The following is a description of a gene set: species: Homo sapiens Human Gene Set: GOCC_ENDOCYTIC_VESICLE_MEMBRANE The lipid bilayer surrounding an endocytic vesicle., and this is the list of marker genes: RAB39A, HVCN1 (NCBI Gene Id 84329), NOS3, SLC9A9, TAPBP, RAB11FIP1, SYT7, SNAP23, TAP2, TLR2, CACNG2, TLR6, IRGM, RAB9A (RAB9A, member RAS oncogene family), SH3GL2, ENTPD7, SYT2, NOSTRIN, RAB8A, ATG5 (NCBI Gene Id 9474), FZD2, MSR1, CLTC, RAB11A, EPGN, ATP6V0D2, LDLRAP1, DLG4 (discs large MAGUK scaffold protein 4), ATP7A, WASL, TCIRG1, TBC1D5, CD9, PICK1, WLS (Wnt ligand secretion mediator), LDLR, FCGR1A, CD74, WNT7A, HLA-H, APPL2, ATP6V0E2 (ATPase H+ transporting V0 subunit e2), CYBB, WNT1, TAP1, SCARF1, HLA-DQA2, CD4, UBC, UBB, DNM2, UBA52, AP2M1, CFTR, ATP6V0A1, CALR, MTMR4, RAB9B, LRP2, ARRB1, HLA-G, HLA-F (NCBI Gene Id 3134), TFRC, HBEGF, AP2B1, TGFA, HLA-DPA1, ADRB2, ATP6V0D1, HLA-DPB1, VAMP2, MARCO, DYNC1LI1, RAC2, WNT6, CAMK2A, HLA-DRB1, RAB11FIP3, AVP, WNT3A, RAB20, AP2A1, ANXA3, CD36, RAB8B, CHRM2 (NCBI Gene Id 1129), APOB, CACNG8, CAMK2B, HLA-B, EREG, CSF3R, PIKFYVE, RAB11B, CD3D, LAMP2, GRIA2, PIK3C3, DMBT1, FZD4, WNT4, MDM2, B2M, SGIP1, LAMP1, SYT1, ATG12, HLA-DRB3, COLEC12, TLR1, RAB7A, VAMP8, CAMK2D, SLC18A3, AP2A2, PIP4P2, ARRB2 (NCBI Gene Id 409), EGFR, CD207, ATP6V0A4, CYBA, RPS27A, PTCH1, ATP6V0A2, SLC15A2, MPEG1, HLA-C, STON2, BTC, INPP5B, IL7R, GRIA1, RILP, ATP6V0E1, SCARB2, BTBD8, SMO, STX4, LRP1, RAB32, CACNG4, FZD5, STON1, KIAA0319, RAB43, RAB23, SLC2A8, PIK3R4, ROR2, RAB31, CAMK2G, STAB1, TYRP1, FCGR1BP, GRIA4, SYT9, WNT5B, HLA-DQA1, EPS15, RAB38, PIP4P1, RAB35, CAV1, HLA-DQB1, SLC48A1, VAMP7, WNT7B, ACE2, GRIA3, HLA-DRA, M6PR, VAMP4, AP2S1, MCOLN1 (NCBI Gene Id 57192), TGOLN2, ATP6V0C, HLA-DRB4 (major histocompatibility complex, class II, DR beta 4), VAMP3 (NCBI Gene Id 9341), ATP6V0B, CD3G, RAB34, LYN, APOE, HLA-E, OCRL, RAB22A, HLA-DRB5, SCARB1, RAB5A, CD163, HLA-DQB2, RAB10, RAB7B, HLA-A, CLEC4E, EGF, SLC11A1, AVPR2, AREG, IGF2R, WNT3, SEC22B, TF, CACNG3, STAB2, WNT5A, CORO1A, GPR161